The following is a description of a gene set: Bilateral choanal atresia studied in species Homo sapiens Bilateral absence (atresia) of the posterior nasal aperture (choana). Human Gene Set: HP_BILATERAL_CHOANAL_ATRESIA, and this is the list of marker genes: TP63, TXNL4A, POLR1A, SLC37A4, FAT4, KMT2D, PAICS, FOXE1 (NCBI Gene Id 7081), DCHS1